Given this list of marker genes CCL5, EFNB1, IL23R, KITLG, LILRB2, PRKCQ, TNFSF13B, BTNL2, FADD, STAT5A, ZP3, SHH, CORO1A, IL1A, PTPRC (protein tyrosine phosphatase receptor type C), HLA-E, CD46, IL1B, CCR2, ZAP70, CD80, TYK2, HHLA2, HES1, IL2RA, IL23A, BMI1, CD24, CD40LG (NCBI Gene Id 959), CD276, TGFBR2, IL4 (NCBI Gene Id 3565), EBI3, IL18, HMGB1, PPP3CA, DNAJA3, SLC7A1, XCL1, PNP, HLA-DPA1, CD3E, NR5A2, RPS3, LEP, CD70, HLA-DMB, IGFBP2, STAT5B, CD1D, PYCARD, CD274, HLA-A, CARD11, CD81, CD6, CD209, SASH3, SELENOK, DHPS, IL6, MIR30B, ZP4, VTCN1, TMIGD2, TFRC, IL12RB1, EPO, JAK2, CLECL1P, CD28, HLA-DPB1, IGF2 (NCBI Gene Id 492304), IL6ST (interleukin 6 cytokine family signal transducer), ICOSLG, TNFRSF13C, NCK1, NCKAP1L, IL12B, HAVCR2, CD4, SLAMF1, NCK2, TNFSF9, TNFSF4, CD86, TRAF6, ANXA1, LGALS9, FOXP3, CCL19 (C-C motif chemokine ligand 19), SPTA1, SPN, IGF1, AGER, RIPK2, CCDC88B, VCAM1, GPAM, IL21, RASAL3 (NCBI Gene Id 64926), PDCD1LG2, SYK, IL15, CD55, AIF1, IL2, MIR21, here is a description of the gene set: Any process that activates or increases the rate or extent of T cell proliferation. studied in species Homo sapiens Human Gene Set: GOBP_POSITIVE_REGULATION_OF_T_CELL_PROLIFERATION